The following is a description of a gene set: Mouse Gene Set: GOMF_CHITINASE_ACTIVITY Catalysis of the hydrolysis of (1->4)-beta linkages of N-acetyl-D-glucosamine (GlcNAc) polymers of chitin and chitodextrins. species: Mus musculus, and this is the list of marker genes: Chil3, Chia1, Chil4, Ctbs, Chil6, Chit1, Chil5, Ovgp1, Chi3l1